Given this list of marker genes MAP2K2 (NCBI Gene Id 85511), NCK1, DCC, AGAP2, RHOA, MYO10, MAPK1, PITPNA, MAP2K1, BCAR1, CAMK2A, MAP1B, UNC5C, CDC42, NTN1, UNC5B, PAK1, WASL, SRC, ELMO1, RAC1, DAPK1 (NCBI Gene Id 1612), MAPK3, FYN, PTK2, PIK3R1, PIK3CA, PLCG1, UNC5A, DOCK1, TRIO, YES1, here is a description of the gene set: Netrin-mediated signaling events species: Homo sapiens from publication Schaefer CF, Anthony K, Krupa S, Buchoff J, Day M, Hannay T, Buetow KH (PMID 18832364) Human Gene Set: PID_NETRIN_PATHWAY